Given this list of marker genes CAMK4, PTCHD1, RELN, ACSS2, SLC2A4, NTF4, CALB1, DRD2, APOE, SHANK1, KAT2A, TACR1, LDLR, PJA2, LCN2, SRF, TAC1, NPAS4 (NCBI Gene Id 266743), SGK1, BTBD9, EIF2AK4, RASGRF1, RGS14, CCND2, CTNS, ADCY8, GRIA1, SLC17A7, PRNP, LRRN4, MECP2 (NCBI Gene Id 8274), CHST10, CPEB3, ARC, CAMK2N1, ADCY1, NFATC4, here is a description of the gene set: The memory process that deals with the storage, retrieval and modification of information a long time (typically weeks, months or years) after receiving that information. This type of memory is typically dependent on gene transcription regulated by second messenger activation. studied in species Homo sapiens Human Gene Set: GOBP_LONG_TERM_MEMORY